The following is a description of a gene set: studied in species Homo sapiens Reactome Pathway: Acetylcholine inhibits contraction of outer hair cells part of: Sensory processing of sound by outer hair cells of the cochlea Outer hair cells (OHCs) are synapsed with efferent cholinergic medial olivocochlear fibers. Acetylcholine released at the synapse binds an unusual, nicotine-antagonized, nicotinic receptor comprising CHRNA9 and CHRNA10. Upon binding acetylcholine, CHRNA9:CHRNA10 transports calcium ions into the OHC. The calcium activates nearby SK2 potassium channels (KCNN2, small potassium current channels) and BK potassium channels (KCNMA1:KCNMB1, big potassium current channels) which extrude potassium ions, hyperpolarize the OHC, and inhibit activation of the OHC.<br>The overall effects of acetylcholine on OHCs are complex. OHCs exhibit fast motility caused by voltage effect on SLC26A5 and slow motility caused by cytoskeleton organization., and this is the list of marker genes: CHRNA10, KCNN2, KCNMA1, KCNMB1, CHRNA9 (NCBI Gene Id 55584)